The following is a description of a gene set: from publication Oswald J, Steudel C, Salchert K, Joergensen B, Thiede C, Ehninger G, Werner C, Bornhäuser M (PMID 16166251) Human Gene Set: OSWALD_HEMATOPOIETIC_STEM_CELL_IN_COLLAGEN_GEL_UP species: Homo sapiens CD34+ hematopoietic stem/progenitor cells (HSCs) reside in the bone marrow in close proximity to the endosteal bone surface, surrounded by osteoblasts, stromal cells, and various extracellular matrix molecules. We used a bioartificial matrix of fibrillar collagen I, the major matrix component of bone, as a scaffold for ex vivo expansion of HSCs. CD34+ HSCs were isolated from umbilical cord blood and cultivated within reconstituted collagen I fibrils in the presence of fms-like tyrosine kinase-3 ligand, stem cell factor, and interleukin (IL)-3. After 7 days of culture, the cell number, number of colony-forming units (CFU-C), and gene-expression profile of the cultured cells were assessed. Although the total expansion factor of CD34+ cells was slightly lower when cells were cultivated in the collagen I gel, the frequency of CFU-C was greater than in control suspension cultures. Gene-expression analysis with microarray chip technology revealed the upregulation of more than genes in the presence of collagen I. Among these, genes for several growth factors, cytokines, and chemokines (e.g., IL-8 and macrophage inhibitory protein 1alpha) could be confirmed using quantitative polymerase chain reaction. Furthermore, greater expression levels of the negative cell-cycle regulator BTG2/TIS21 and an inhibitor of the mitogen-activated protein kinase pathway, DUSP2, underline the regulatory role of the extracellular matrix. Together, these data show that the expansion of CD34+ cord blood cells in a culture system containing a three-dimensional collagen I matrix induces a qualitative change in the gene-expression profile of cultivated HSCs. Genes up-regulated in hematopoietic stem cells (HSC, CD34+) cultured in a three-dimentional collagen gel compared to the cells grown in suspension., and this is the list of marker genes: DND1, BIRC3, ATL2, F3, PLK2, CCR9, LARP1, DSTYK, HIPK1, SF3B1, TNFAIP3, GGCX, KAT2A, BAG5, TIPIN, HNRNPA1, NR4A2, RHOQ, PALM2AKAP2, CD44, ZC3H12A, EREG, H1-10, GCLC, IER5, SBSPON, EIF3M, SLC12A2, AMIGO2, FOSB, SGK1, AHCYL1, SEC23IP, SZRD1, IL12A, AGAP1, PSME4, EPB42, NFE2L2, RHOBTB3, CXCL1, ENSG00000275616, CXCL3, NR5A2, IL1B, ADNP2, NUP160, DUSP2, ATF3, TGM4, CTSL, HOOK1, CHEK1, TOR1AIP2, PTX3, GADD45B (NCBI Gene Id 4616), MAGEH1, EGR1, SF3A3, SEPTIN8 (septin 8), PIK3C2B, H3-3B, NF1, HCAR3, AVPR1A, COL2A1, RUNX1, RAB11FIP1, PKP4, TAC3, RAB5C, DAB2, ARL4C, AKAP13, FAM117A, PROX1, KPNB1, CCN3, BCL2A1, FZD7, PHF14, GAD1, KLF6, CXCL10, IL1RN, GALNT2, CXCL2, IL2RB, RASSF4, CDK5R1, SPRY2, TIPARP, ZFP36, ROM1, SOD2, SLCO2B1, ALAD, FH, ODF2, YRDC, CD14, IER3, PTGER4, AKR1C1 (NCBI Gene Id 9418), FERMT2, CIRBP, CFLAR, MAFF, TFAP2A, SPSB1, AKR1C3, CASQ1, LINC00667, CHD3, JUNB, ADD1, CDKN1A, PHOX2A, PEG10, SKP2 (NCBI Gene Id 86997), SMC3, SPA17, BRD4, SRRM1, MCL1, ARMC8, PTGS2, SIK3, VPS37B, DNAJC8, IL1A, ETS2, KDM4B, FUS, AREG, HNRNPDL, DLEU2, IL1R2, USP46, NFKBIA, HOMER3, TNF, NAP1L1, PPP4R3B, SLC7A1, KLF2, BTG2, TUBA3C, TBC1D5, CTNNBL1, ACSL6, LAS1L, GPR183, FOS, MTOR, CD83, KLF4, RHAG, DDX3Y (DEAD-box helicase 3 Y-linked), RGS2, CYP1B1, CA1, SSB, KLF9, LEF1, ARL4A, FLNC, GPS2, DUSP1, ZFP36L1, SERPINB2, KCNJ2 (potassium inwardly rectifying channel subfamily J member 2), TNFAIP6, TIMM17A (translocase of inner mitochondrial membrane 17A), CCL2, RPL23, CCL4, ICAM1, CRISP2, PDE4B, PAFAH1B2, EGR3, ABCG2, HRH4, EHD1, RGS1, GCFC2, NREP, IL6, ANGEL2, TREM1, C3AR1, HK2-DT, POU4F1 (NCBI Gene Id 730659), ZWILCH, GATAD2A, TCF4, TRIB1, LUC7L3, HGF, ALDH1A1, PSMD11, F7, EDEM3, GANAB, FBXO11, IER2, DHRS9, PRRC1, RNASE1, PPP1R15A, JUN, GRAP2, CDC42EP3, CENPI, CXCL8, MAOB, ACSM3, MAPK3, CCL3, COL15A1 (collagen type XV alpha 1 chain), AHSP, FBN1, RCC1